Given this list of marker genes NDUFAF1, PSTK, WDR11-DT, BPGM, RPL4, DMAP1, IPO4, RPL37, PHYH, PCYT1A, SMG8, RBBP5, ZNF579 (zinc finger protein 579), GIN1, TUT1, STUM, DMKN, PSMB6, MTR, ZNF213-AS1, LINC02896, POLR3B, DNASE1L1 (deoxyribonuclease 1 like 1), MYH14 (myosin heavy chain 14), MBTPS2, TMEM242, SYNRG, EYA3 (NCBI Gene Id 2140), SMG7-AS1, PPIP5K2, EWSAT1, ENPP3, MKS1, ADAP2, EME2, UBE3B, GPHA2, ZDHHC6, METTL15, SCAND1, ENSG00000232995, IFT56, ZWILCH, VARS2, DSCC1, SNORA71B, TP53BP2 (NCBI Gene Id 7159), NOP16, TBC1D19, GFM2, AP3S2, IBTK, TMEM69, UTP3, WDR11, WDR36, PSMD3, TEFM, LSG1, MAP2K1, TAFAZZIN, SMG7, JPX (NCBI Gene Id 647596), ZNF302, RRM2B, AP3B2, ZNF205, DRAIC, CNBD2, ZNF227, GTF2H4, TARS2, C10orf88, GPBP1L1, MTND5P11, MTCO3P12, DHX33-DT, UBR5-DT, EFCAB7, MIR525 (microRNA 525), CDC42SE1, NSA2 (NSA2 ribosome biogenesis factor), PPM1K, DSTYK, NBPF1, ENDOG, TAOK1, CACYBP, GABPB2, FAM98B, MRPS34, TMEM79, VTRNA1-2, MRPL44, MTOR, AURKAIP1, KCTD10, BMS1, NUF2, NME1, NUDT19-DT (NUDT19 divergent transcript), SLC24A1, ITGB3BP, TMA16, RNVU1-27, PHIP (pleckstrin homology domain interacting protein), SF3A3, GOLGA3 (NCBI Gene Id 2802, golgin A3), NDUFS7, RAD1, RGS5, C19orf12, NUDT19, THAP10, ZNF461, DRG2, CCNC, C17orf75, INTS14, WDR24, TIPIN, INTS5, SMG5, C11orf52, BRF2, SERP1, CCDC24, VTI1A, ZNF131 (zinc finger protein 131), MED23, MAN2C1, DHX33, TMEM130, LIN37, COX16, TMEM242-DT, LRRC49, FRA10AC1, WARS1, BRIX1, ZNF609, CCAR2, PRC1, MRPS31P4, NME1-NME2, SMARCD2, CDK5RAP1, here is a description of the gene set: Human Gene Set: ZNF667_TARGET_GENES Genes containing one or more binding sites for (ZNF667) in their promoter regions (TSS -1000,+100 bp) as identified by GTRD version 20.06 ChIP-seq harmonization. from publication Yevshin I, Sharipov R, Kolmykov S, Kondrakhin Y, Kolpakov F (PMID 30445619) species: Homo sapiens